The following is a description of a gene set: Human Gene Set: GOBP_ENTEROENDOCRINE_CELL_DIFFERENTIATION The process in which a relatively unspecialized cell acquires specialized structural and/or functional features of an enteroendocrine cell. Enteroendocrine cells are hormonally active epithelial cells in the gut that constitute the diffuse neuroendocrine system. species: Homo sapiens, and this is the list of marker genes: INSM1, WNT5A, CDK6, MIR541, GSK3B, NKX2-2, IER3IP1, NKX6-3, AKT1, BAD, SMO, CDH2, BMAL1, PERCC1, GATA6, NKX6-1 (NK6 homeobox 1), PDPK1, GDF11, PAX6, BMP5, DLL1, RFX6, RHEB (Ras homolog, mTORC1 binding), BMP6, SIDT2, CLOCK, HES1, ASCL1, NKX6-2, ONECUT1, BMP4, NEUROD1, RFX3, GSK3A, BHLHA15, RBM4, PAX4, PDX1